The following is a description of a gene set: Any process that stops, prevents or reduces the frequency, rate or extent of a ceramide biosynthetic process. studied in species Homo sapiens Human Gene Set: GOBP_NEGATIVE_REGULATION_OF_CERAMIDE_BIOSYNTHETIC_PROCESS, and this is the list of marker genes: ORMDL1, ORMDL3, PRKAA1, SPHK1, ORMDL2